The following is a description of a gene set: from publication Elo LL, Järvenpää H, Tuomela S, Raghav S, Ahlfors H, Laurila K, Gupta B, Lund RJ, Tahvanainen J, Hawkins RD, Oresic M, Lähdesmäki H, Rasool O, Rao KV, Aittokallio T, Lahesmaa R (PMID 20620947) Genes up-regulated in comparison of CD4 T cells treated with IL4 and anti-IL12 at 4 h versus the untreated cells at 4 h. Human Gene Set: GSE17974_IL4_AND_ANTI_IL12_VS_UNTREATED_4H_ACT_CD4_TCELL_UP The aim of this dataset was to study in detail the transcription kinetics initiated by cytokine IL-4 in early differentiation of Th2 cells. species: Homo sapiens, and this is the list of marker genes: R3HCC1L, MAVS, SLC26A11, VCL, DOLPP1, CAMK2D (calcium/calmodulin dependent protein kinase II delta), RNF24, IRS2, RNPEP, SLC25A11, H4C1, LRP2BP, GPR83, CCDC9B, AP1B1, HPGD, DOCK7, PDE9A, EMILIN2, REXO4, A2M-AS1, DZIP3, IL10RA, SYTL3, TTC9C, BTN2A1, MAST3, MGME1, TNFRSF14, MTFR1L, C6orf89, ANKRD36BP2 (ankyrin repeat domain 36B pseudogene 2), OSBPL1A, NLGN4Y, SWAP70, APOL6, BSCL2 (NCBI Gene Id 84753), SNX8, C8orf74, BTN3A3, IRAK4, MZF1 (NCBI Gene Id 90814), KHK, RIPK2, SMPDL3A, PPARG, ADIG, SGSH, PLXDC1, BLTP2, FGF14-IT1, KDM7A, MOB3C, DENND10, SYS1, DLC1, REEP1, APEH, EPAS1, PTGER2, GPAA1, UBE2NL, TMEM39B, CD8A, RALB, SULF1, LINC01619, JAK2, MGAT1, C12orf76 (chromosome 12 open reading frame 76), GGTLC1, PAN2, RPS6KB2, CDK2, PRSS22, CTSK, DDB2 (damage specific DNA binding protein 2), ALDH16A1, HTT, DMRTA2, SOCS1, TADA3, GCOM1, SLCO3A1, VSIG10L, LTC4S, SYNE1, SLC39A8, ZNF589, TBC1D17, C17orf58, CCDC97, PTPN4, MACROH2A2, UBAC1, PITRM1, MED20, PLPP1, CYP51A1-AS1, ZNF443, POLL, MCM5, SPIRE2, AIFM1, MIR600HG, IDH2, GUCY1B1, RFC1, C1GALT1C1L, POMT1, DHX58, STAT4, STK19, DPH3P1, PINLYP, IMMT, VAMP5, SSBP2, RAB30, ABCD4, ETFB, TBC1D14, TPRG1, STN1, SLC37A3, PLEKHO1, LINC01550, MAP3K14, CCRL2, NIPA1, KIAA0586, MAP4K1, H2BC21, YIF1B, ACBD6, B3GALT2, MTOR, GAB3, TEX30 (testis expressed 30), ELAPOR2, RAB27B, FARP1, CIZ1, IGSF11, RHPN2, TESPA1, SMIM17, CLUL1, HHIP-AS1, PYCR1, PLOD3, CD8B, SCN3A, GAB2, IL4R, TMEM9, PLLP, RBM4B, ZFYVE19, SLC35E2A, LINC01181, MYO7A, MOB2, STX16, TREML2, TRABD2A, ZBTB16, ADAM8, ZNF595, DUSP6, TGFBR3, GATA3, ACD, SPINT2, COG4 (NCBI Gene Id 25839), SMG9, PRMT2 (NCBI Gene Id 3275), GPATCH3, HAUS4, LORICRIN, NECAP2, ULK1, LRSAM1, TMEM187, MCF2, NBEAL2 (neurobeachin like 2), RPRML, WRNIP1, PAOX, KCNK6, SLC9A7, GBA2, CDC42EP5